Given this list of marker genes PRKAG1, PRKAB1, PRKAG3, PRKAB2, MAPK14, PPARGC1A, PRKAG2, PRKAA2, MAPK11, MAPK12, here is a description of the gene set: species: Homo sapiens Reactome Pathway: Activation of PPARGC1A (PGC-1alpha) by phosphorylation The transcriptional coactivator PPARGC1A (PGC-1alpha), one of the master regulators of mitochondrial biogenesis, is activated by phosphorylation. Energy depletion causes a reduction in ATP and an increase in AMP which activates AMPK. AMPK in turn phosphorylates PPARGC1A. Likewise, p38 MAPK is activated by muscle contraction (possibly via calcium and CaMKII) and phosphorylates PPARGC1A. PPARGC1A does not bind DNA directly, but rather interacts with other transcription factors. Deacetylation of PPARGC1A by SIRT1 appears to follow phosphorylation however the role of deacetylation is unresolved part of: Mitochondrial biogenesis